Given this list of marker genes TYMS, SLIT2, IVNS1ABP, GPR61, CENPP, KLK4, TXNDC8, SGCD, RABGEF1, HELZ, TMEM30B, MPIG6B, MED30, TFAP2A, ARL6, SUMO1, RRP7A, BEAN1, S100A10, STRIP2, CPEB4, SHISA7, ZNF782, CNNM2, CANX, ENPP5, C9orf57, KIF3B, DNAH8, RAPH1, CYP2C18, PDE6D, PMS1, ZNF592, HTRA1, SLC12A6, SNF8, HMX2, FOXD4L3, CREB1, FZD2, ARMC9, GNAQ, WNK3 (WNK lysine deficient protein kinase 3), MBNL3, GPR183, SNRPN, COX15, PSMD5, KIF16B, WNK1, CNN3, LURAP1, MBNL2 (NCBI Gene Id 55479), KIAA1210, IL23R, AP1G1, CASTOR3P, IRF2, here is a description of the gene set: studied in species Homo sapiens Human Gene Set: MIR6834_5P from publication Chen Y, Wang X (PMID 31504780) Genes predicted to be targets of miRBase v22 microRNA hsa-miR-6834-5p in miRDB v6.0 with MirTarget v4 prediction scores > 80 (high confidence targets).